Given this list of marker genes Drd1, Ddo, Slc1a1, Oxt (oxytocin), Dlg4, Drd2, Ctns, Nrxn1, Avp, Nmur2, Avpr1a, Mc4r, Kcnq2, Cntnap2, Htt, Shank3, Aprt (NCBI Gene Id 97468), Nmu, Hoxb8, Hprt1, Cntnap4, Slitrk5, Qrfp (NCBI Gene Id 227717), Ppt1, here is a description of the gene set: Mouse Gene Set: GOBP_GROOMING_BEHAVIOR studied in species Mus musculus The specific behavior of an organism relating to grooming, cleaning and brushing to remove dirt and parasites.